Given this list of marker genes TIA1, MORC2, RPIA, MYPN, UBE3A, TCF20, CAPN3, NR4A2 (NCBI Gene Id 4929), NKX2-1, CACNA1A, PLA2G6, MICU1, BBS1, NTN1, PAK3, GABRA1, ATP9A, NOP56, HSD17B10, HCN1, GABRD, TANGO2, SCN2A, RDH11, KBTBD13, LZTFL1, CLTC (clathrin heavy chain), NIPA2, GRID2, TTC19, STX1B, RNF125, SQSTM1, SPTBN2, SLC6A8, EEF1A2, GPRC5B, NADK2, ARSA, TGM6, MED13L, CWF19L1, TCF4, SDHA (succinate dehydrogenase complex flavoprotein subunit A), CHD8, CLN5, DARS2, CLN8, HNRNPA1, CLCNKB, ACOX1, SYNE1, SPTAN1, TINF2, ATP7B, TPP1, CHAMP1 (chromosome alignment maintaining phosphoprotein 1), MPZ (NCBI Gene Id 4359), MECR, ERCC4, ADGRV1, KDM4B, GABRG2 (gamma-aminobutyric acid type A receptor subunit gamma2), DEAF1, CARS1, SCN9A, PMPCA, TSHB, GRIN2A, HEXB, ABCD1, HTT, YWHAG, HUWE1, TPR, RAD51, SNRPN, SLC52A2, PCDH19, ASAH1, SCO2, SLC18A2, ACTA1, CLCN1, MAN2B1, KLHL41, GCH1, ATXN8OS, ATP1A3, BCKDK, MLXIPL, ELP1, TRANK1, DCC, EEF2, TTPA, HAX1, TUBG1, TXN2, ATXN3, PSAP, SLC25A15, SLC39A14, RNF168, NAA20, SCN1A, KCND3, CCDC28B, PRNP, KCNC3, ARL6, DNAL4, ALG13, PDE2A, HLA-DQB1, PMP22, MPV17, CLCNKA, TWNK (twinkle mtDNA helicase), LMBRD1, CREBBP, APC2, SCN1B, PANK2, HEPACAM, POGZ, EP300, MTFMT, NSD1, LYST, CDC42BPB, CPLX1, NEB, RORA, EED, SET, TPM3, TTN, TBC1D23 (TBC1 domain family member 23), GALC (galactosylceramidase), MTR, ATP2B3, MAPT, SLC2A3, FRRS1L, ABCA2 (NCBI Gene Id 23153), POLR3A, SYNGAP1, AASS, KCNA1, ATXN10, AQP4, SLC22A5, BSND, SPG21, ELN, SLC52A3, TBC1D24, GJB1, GALT, TPM2, MTHFR, CAV3, AFF2, ENSG00000288330, PRRT2, DYRK1A, NIPA1, ALMS1, FXN, SIM1, HLA-DRB1, FGF13, here is a description of the gene set: species: Homo sapiens Incoordination Human Gene Set: HP_INCOORDINATION